The following is a description of a gene set: studied in species Homo sapiens Human Gene Set: GOMF_SOLUTE_MONOATOMIC_CATION_SYMPORTER_ACTIVITY Enables the transfer of a solute or solutes from one side of a membrane to the other according to the reaction: solute(out) + cation(out) = solute(in) + cation(in)., and this is the list of marker genes: SLC17A2, SLC5A2, SLC16A3, SLC39A5, SLC38A3, SLC15A1, SLC10A2, SLC36A3, SLC6A15, SLC12A8, SLC6A9, SLC11A2, SLC1A1, SLC6A13, SLC5A3, SLC39A14, SLC38A7, SLC23A2, SLC29A1, SLC10A1, SLC6A18, SLC6A20, SLC45A1, SLC23A1, SLC12A1, SLC5A9, SLC6A7, SLC20A1, SLC45A2, SLC17A6, SLC38A4, SLC15A3, SLC6A12, SLC4A9, SLC6A1, SLC38A2, SLC12A2, SLC15A2, SLC10A6, SLC17A3, MFSD2A, SLC18A1, SLC39A6, SLC1A7, CTNS, SLC1A6, SLC5A8 (solute carrier family 5 member 8), SLC45A3, SLC6A3, SLC36A2, SLC5A12, SLC17A5, SLC12A5, SLC5A5, SLC2A13, SLC1A2, SLC34A1, SLC13A1, SLC13A2, SLC34A3, SLC25A22, SLC4A5, SLC12A7, SLC13A3, SLC2A9, SLC6A14, SLC28A3, SLC34A2, SLC32A1, SLC16A1, SLC39A12, SLC17A1, SLC5A6, SLC4A7, SLC13A4, SLC22A1, SLC46A1, SLC10A4, SLC39A10, SLC10A5, SLC6A5, SLC13A5, SLC1A3, SLC4A4, SLC5A11, SLC28A2, SLC39A4, SLC28A1 (solute carrier family 28 member 1), SLC5A1, SLC18A2, SLC5A10, SLC4A8, SLC17A7 (solute carrier family 17 member 7), SLC25A3 (solute carrier family 25 member 3), SLC17A4, SLC20A2, SLC36A1 (NCBI Gene Id 91974), SLC2A10, SLC6A4, SLC6A6, SLC12A3, SLC15A4, SLC25A18, SLC12A9, SLC45A4, SLC12A6, SLC6A8, SLC39A8, SLC10A3, SLC12A4, SLC5A7, SLC17A8, SLC6A11, SLC5A4, SLC38A1, SLC6A2, SLC4A10